The following is a description of a gene set: Any process that activates or increases the frequency, rate or extent of double-strand break repair via homologous recombination. studied in species Mus musculus Mouse Gene Set: GOBP_POSITIVE_REGULATION_OF_DOUBLE_STRAND_BREAK_REPAIR_VIA_HOMOLOGOUS_RECOMBINATION, and this is the list of marker genes: Ruvbl2, Actr2, Fancb, Ercc6, Prmt1, Epc1 (enhancer of polycomb homolog 1), Wdr48 (NCBI Gene Id 67561), Meaf6, Kat5, Actb, Parp1, Vps72, Wrap53, Dmap1, Trrap, Ing3, Helq, Khdc3, Brd8, Hdgfl2, Ooep, Morf4l2, Rnf126, Rnf8, Epc2, Fus, Skp2, Mrnip, Timeless, Rad51ap1, Pias4, Ep400, Yeats4, Ruvbl1, Actl6a, Arid2, Morf4l1, Mrgbp, Was, Crebbp, Blm, Mbtd1, Peli1